The following is a description of a gene set: Human Gene Set: GOBP_SECRETION_BY_TISSUE The controlled release of a substance by a tissue. studied in species Homo sapiens, and this is the list of marker genes: WNK4, AQP5, LACRT, WNK1, CYBA, ATG5, WNK3, AGR2, STATH, NR1H3, PPP3CA, SCT, TIFAB, COPA, NR1H2, CELSR2, VAMP8, CHRM3, KCNN4, OPRK1, VAMP2, SCNN1B, TP73, CHRM1, ANO1, DCANP1, TRAF3IP2, ADA, SLC4A9, PRICKLE1, MUC2, NEGR1, CEL, P2RY2, VAMP3, ALOX12B, FGF10, NLRP6, STK39 (serine/threonine kinase 39), NKX2-3 (NCBI Gene Id 53631), AQP1, NEUROG1, FOSL2 (FOS like 2, AP-1 transcription factor subunit), SLC4A5, HTR4, PRKCE, ADORA1